The following is a description of a gene set: RNA Polymerase III Transcription Initiation From Type 3 Promoter Mouse Gene Set: REACTOME_RNA_POLYMERASE_III_TRANSCRIPTION_INITIATION_FROM_TYPE_3_PROMOTER studied in species Mus musculus, and this is the list of marker genes: Polr3b, Polr3f, Polr2e, Polr2h, Snapc1, Brf2, Polr3k, Polr3h, Crcp, Snapc5, Snapc2, Polr3g, Polr2l, Polr3e, Polr3gl, Snapc4, Polr3d, Snapc3, Polr2f, Polr3c, Tbp, Pou2f1, Bdp1, Polr1c, Polr2k, Polr3a